Given this list of marker genes Pdgfc, Angpt1, Chrna3, Prlr, Nrg1, here is a description of the gene set: Any process that initiates the activity of the inactive transmembrane receptor protein tyrosine kinase activity. studied in species Mus musculus Mouse Gene Set: GOBP_ACTIVATION_OF_TRANSMEMBRANE_RECEPTOR_PROTEIN_TYROSINE_KINASE_ACTIVITY